Given this list of marker genes Btnl2, Mapk14, Tnfsf4, Dhps, Lck, Nf2, Magi1, Sox12, Sox13, St3gal4, Itga4, Cd1d1, Cd55b, Epo, Gimap5, Tmem131l, Megf10, Ceacam1, Epcam, Bmi1, Ap3d1, Lgals8, Aif1 (NCBI Gene Id 56250), Casp3, Tnfsf14, Dpp4, Rap1gap, Il1rl2, Dennd6a, Fadd, Abl2, B2m, Il2rg, Ager, Tnf, Ass1, Jag1, Bmp4, Il4ra, Card11, Cd69, Crtam, H2-Ob, Arg2, Icos, Runx3, Dusp10, Bcl10, Ccdc88b, Slc7a1, Cx3cl1, Nfkbiz, Flot1, Il10, Plaur, Cited2, Anxa1, Ifnb1, Tfrc, Rc3h2, Ido1, Lax1, Flot2, Lef1, Il7, Ets1, Irf1, Cd46, Sart1, Tmx1, Zp3, Ccm2l, Cd40lg, Il23a, Tnr, Ceacam2, Zmiz1, Tnfrsf21, Tnfrsf13c, Cyrib, Ptprc, Itgb2, Slc4a1, Scgb1a1, Sfn, Opa1, Tnfsf13b, Itgal, Bad, Socs6, Hspb1, Nkap, Rasgrp1, Smarcc1, Taok2, Elane, Kifap3, Carmil2, Pck1, Ephb3, H2-Aa, Prkcq, Efnb3, Mettl3, Ywhag, Il6ra, Pik3r1 (NCBI Gene Id 328326), Dock8, Zc3h12a (zinc finger CCCH type containing 12A), Vav1, Cebpb, Ccl19, Prkcz, H2-DMb2, Il7r, Fgl2, Gcnt2, Sh2b3, Ccl21f, Akt1, Mmrn1, Havcr2, Clec4g, Fut7, Il2ra, Cd44, Irak1, Btn2a2, Hlx, Cd276, Nr4a3, Ccl21e, Brd2, Ildr2, Actb, Cd300a, Zc3h8, Il6st, Pycard, Cd59b, Dtx1, Tenm3, Tespa1, Cd28, Fga, Swap70, Arid1a, Pkp3, Cdh1, Brd4, Zfp608, Cd3e, Rgcc, Zc3h12d, Ptpn23, Prkaa1, Zfp609, H2-DMa, Chst2 (carbohydrate sulfotransferase 2), Pik3r6, Wnt1, Lilrb4a, Gnrh1, Fut4, Tigit, Peli1, Dnaja3, C1qtnf1, Mapk7, Ptpn6, Abca12, Piezo1, H2-DMb1, Pbrm1, Pla2g5, Ifng, Tnfsf11, Epha7, H2-Ea, Lep, Ccl28, Prkcd, Sox4, Cyld, Smarcd1, Actl6a, Pten, Lgals3, Slamf1, Wnt5a, Il36b, Gpnmb, Src, Dlg5, Cblb, Nrarp, Klf4 (NCBI Gene Id 269540), Gcnt1, Adipoq (adiponectin, C1Q and collagen domain containing), Ephb6, Stat5a, Icosl, Ripor2, Tnfaip3, Selp, Pdpn, Alox15, Tbx21, Cd37 (NCBI Gene Id 12493), Pdcd1lg2, Ppm1f, Lilrb4b, Ptpn2, Dapl1, Blm, Tgfbr2, Twsg1, Ccl2, Nck2, Vnn1, Cd27, H2-T23, Ptpn22, Foxo3, Ascl2 (achaete-scute family bHLH transcription factor 2), Fcho1, Muc21, H2-Eb2, Zbtb1, Il12rb1, Il15, Pnp, Vsig4, Gp1ba, Kat5, Ccl25 (NCBI Gene Id 320542), Cbfb, Apoa1, Trpv4, Prnp, H2-M3, Emilin2, Mir326, Mink1, Plpp3, Kif26b, Bmp6, Itch, Afdn, Ep300, Adam8, Hspd1, Tyk2, Cd86, Fgl1, Efnb1, Arg1, Pcdh8, Ctla4 (cytotoxic T-lymphocyte-associated protein 4), Mad1l1, Igf1, Fgg, Ccl5, Sftpd, Cd274, Gli3, Adam19, Mfsd2b, Egr3, Arid2, H2-Oa, Btla, Bmp2 (NCBI Gene Id 98992), Foxp3, Rdx, Pdcd1, Fbxo38, Sash3, Wnt3a, Ccr7, Ndfip1, Il21, Adora2a, Ctsg, Klhl25, Spn, Cd209d, Smarcb1, Emilin1, Lgals1, Ambra1, Selenok, Cxcl13, Bmp7, Marchf7, Hmgb1, Il4i1, Mia3, Il6, Adamts18, Tarm1, Myo10, Tnfrsf14, Ank3, Cd4, Shb, Fermt3, Nfkbid, Erbb2, Cd81, Map2k1, Il3, H2-Ab1, Muc4, Ripk2, Wnk1, Ppp3ca (protein phosphatase 3, catalytic subunit, alpha isoform), Il20rb, Gtpbp4, Zdhhc2, Ccl21d, Rhoa, Rasal3, Klhl22, Shh, Notch1, Mdga2, Ccl21b, Xcl1, Ada, Nexmif, Coro1a, Mex3b, Alox12, Loxl3, Il4, Lgals9, Zdhhc21, Sox2, Sdc4, Tnfsf9, F11r, Zfp35, Cd74, Igfbp2, Celsr2, Specc1l, Epb41l5, Ptpru, Spint2, Slfn1, Socs5, Ephb4, Has2, Sirpa, Il2 (interleukin 2), Ccr2, Ubash3b, Thy1, Brd7, Pde4d, Vcam1, Wnt10b, Jak3, Foxj1, Il18, Itga6, Tgfb1, Ythdf2, Rag1, Ihh, Nr5a2, Wnt4, Cd80, Rnase10, Cd47 (NCBI Gene Id 78539), Jak1, Glmn, Il1a, Smarca4, Itpkb, Hfe, Traf6, Hes1, Stat5b, Capn1, Malt1, Spta1, Vegfa, Cd1d2, Smarca2, Sele, Vsir, Jak2, Smarce1, Cd244a, Htr2a, Pla2g2a, Fgb, Skap1, Icam1, Irgm1, Cd9, Vtcn1, Ptafr, Pkhd1, B4galnt2, Serpine2, Phf10, Skint1, Prkar1a, Dlg1, Ap3b1, Pla2g2f, Tspan32, Cdkn2a, Runx1, Cd160, Rela, Cd83, Xbp1, Notch4, Socs1, Tnfaip8l2, Cd209c, Map2k5, Pf4, Pag1, Mad2l2, Ccr5, Tjp1, Rps3, Tsc2, Ppara, Prdx2, Cd24a, Efna5 (NCBI Gene Id 13640), Cxcl12, Smad7, Abl1, Ccl21a, Gimap3, Laptm5, Slc4a2, H2-Eb1, Cd6, Cdsn, Scrib, Nlrp3, Tnfsf18, Rc3h1, Nck1, Nckap1l, Pawr, Pla2g2d, Dusp22, Il12a, Zbtb7b (NCBI Gene Id 22724), Efnb2, Rag2, Podxl, Igf2, Ufl1, Cd55, Syk, Dusp3, Lrfn3, Gata3, Pde5a, Magi2, Alox5, Il12b, Smarcd3, Gpam, Akna, Spi1, Pkp1, Mdga1, Fstl3, Fut9 (NCBI Gene Id 14348), L1cam, Prkg1, Cela2a, Hsp90aa1, Cd5, Zfp703, Lrrc32, Cd209e, Ptk2, Cd59a, Gstp1, Lag3 (NCBI Gene Id 16768), Rhoh, Mbp, Vps33b, Smarcd2, Prkca, Tbx18, Smarcc2, Adtrp, Cav1, Lyn, Adk, Rara, Actl6b, Il1rn, Bcl6, Zap70, Mdk, Nodal, Kitl, Il1b, Chst4, Nfat5, Myadm, Hsph1, here is a description of the gene set: Mouse Gene Set: GOBP_REGULATION_OF_CELL_CELL_ADHESION Any process that modulates the frequency, rate or extent of attachment of a cell to another cell. studied in species Mus musculus